The following is a description of a gene set: Ageing of the brain leads to impairments in cognitive and motor skills, and is the major risk factor for several common neurological disorders such as Alzheimer disease (AD) and Parkinson disease (PD). Recent studies suggest that normal brain ageing is associated with subtle morphological and functional alterations in specific neuronal circuits, as opposed to large-scale neuronal loss. In fact, ageing of the central nervous system in diverse mammalian species shares many features, such as atrophy of pyramidal neurons, synaptic atrophy, decrease of striatal dopamine receptors, accumulation of fluorescent pigments, cytoskeletal abnormalities, and reactive astrocytes and microglia. To provide the first global analysis of brain ageing at the molecular level, we used oligonucleotide arrays representing genes to determine the gene-expression profile of the ageing neocortex and cerebellum in mice. Ageing resulted in a gene-expression profile indicative of an inflammatory response, oxidative stress and reduced neurotrophic support in both brain regions. At the transcriptional level, brain ageing in mice displays parallels with human neurodegenerative disorders. Caloric restriction, which retards the ageing process in mammals, selectively attenuated the age-associated induction of genes encoding inflammatory and stress responses. from publication Lee CK, Weindruch R, Prolla TA (PMID 10888876) Human Gene Set: LEE_CALORIE_RESTRICTION_NEOCORTEX_UP studied in species Mus musculus Up-regulated in the neocortex of aged (30-month) mice subjected to caloric restriction since young adulthood., and this is the list of marker genes: GPR19 (G protein-coupled receptor 19), NAA80 (NCBI Gene Id 24142), GABRA2, PRKD1, POLE3, CNOT2, SLC12A2, PCNA, NPRL2, KHDRBS1, RELB, LDB1, DTNA, SAMHD1, UBA7, DRD4, FABP5, PPIC, TLE1, SLC6A15, HINT2, BMP1, STK39, HOXA6 (homeobox A6), HOXB9, KIAA2013, SELP, EDN2, PPEF2, KMT2B, MTIF2, TFDP1 (NCBI Gene Id 7027), IFNA8, ACTA1, HOXB3, EIF2AK3, MAFF, LONP1, MSH2, OSBP2, UMPS, ZBTB7A, KLC1, CSK, SERPINE1, AQP4, E4F1, THBS3 (thrombospondin 3), CES1, TNNC1, CIT, GAS6, CBLIF, ATP13A2 (NCBI Gene Id 63919), ASIP, ANXA6, ZNF771, PF4, PURA, PTPRD, OPRD1, NFKBIA, BAG6, TSC22D1, GATA4, TYMS, GJA3